Given this list of marker genes NTN1, WDR83 (NCBI Gene Id 84292), DVL2, TGFB1, RORA, MIR2355 (NCBI Gene Id 100423036), TGFB2, NPPB, OVOL2, BMPER, MIR145, NFE2L2, TAL1, NPPC, ITGB1BP1, CEP290, FN1, RBPJ, COL8A2, TMIGD2, NRCAM, PRDM1, ACTG1, COMP, CD40, HMOX1 (heme oxygenase 1), CUL7, C3, TMEM201, HS3ST3A1, KRIT1, ABCC8, TGFA, PPP1R16B, MINAR2, OR10J5, MTHFD1L, STIM1, CDH2, MMP2, CD34, TAFA5, CLEC14A (C-type lectin domain containing 14A), ADGRG6, IL12B, SLC39A12, RLN2 (NCBI Gene Id 6019), OTULIN, MIR1298, ENG, ROCK2, CD47, SEMA5A, MICALL1, CAV1, MIR15A, PTPRJ (protein tyrosine phosphatase receptor type J, NCBI Gene Id 5795), MEIS3, CEMIP2, ST14 (NCBI Gene Id 6768), CSF1, FASLG, SRF, MIR181B1, ARHGAP24, SOX11, TIPARP, EGR3, WNT7B, GATA4, NPNT, RPS7 (ribosomal protein S7), GLMN, ADIPOR2, NCKAP1, CCDC103, WNT6, EHD4, PRKCB, TRIM71, CXCR3, NOTCH3, MTDH, PTGS2, AR, GPX1, TLR3, COL3A1, AMOT, EYA1, MIR483, MIR153-1, RBM15, GDF7, LHX2, ACVRL1, CLDN5, MIR199B, VEZF1, MIR200C, SASH1, CARD10, PRKACB, MAPK7, MYCN, CTSZ, VASH2, ATP5IF1, SEC24B, FGF8, CELA1, SLC12A6, MIR503, PTK2B, GPR4, CSPG4, ZEB1, ECSCR, MCAM, KRAS, ILK, PRKD1 (NCBI Gene Id 5587), CXCL13, TSC1, IRX3, MIR199A1, WNT3A, NR3C1, MIR18A, DNAAF1, PGK1, CCDC39, YJEFN3, AQP1, EDN1, TJP1, ACKR3 (atypical chemokine receptor 3), TSC2, MIR23A, TERT, RDH10, SMAD1, HLA-G, CLIC3, TNFRSF12A, EMC10, RSPO2, IFT57, SARS1, CTSH, WNT11, PIK3C2A (NCBI Gene Id 5286), TBX1, MED1, F3, PDCL3, MIR492, PDCD10, EGFR, CCBE1, NR2E1, ATP2B4, ERBB2, YAP1, KLHL3, STARD13, MIR196A1, FOXC2, EMP2, MIR101-1, FZD3, SMAD3, MTHFR (NCBI Gene Id 4524), NR2F2, CLIC4, MIR495, RSPO3, CHI3L1, MTHFD1, MMRN1, PRKACA, PIK3R6, NOTCH2, MIR99B, GAB1, EGFL8, HESX1, IGFBP7, CXCL17, NKX2-3, COL4A3, TEK, MIRLET7A1, GLI3, IL6, DLL1, HEG1 (NCBI Gene Id 57493), NOX5, BCL2, PDGFA, ANPEP, EPHB3, KDM2B, PF4, SEMA3E, BAK1, LRP2, MAPK14, EFNA1, E2F7, XBP1, MIR146A, CCN2, TBX3, RTN4, MIR31, C1GALT1, DDAH1, PIK3CA (phosphatidylinositol-4,5-bisphosphate 3-kinase catalytic subunit alpha), PRKCA, RELA, HOXA11, CLUAP1, ADAM8, ANGPT2, MIR130A, GPNMB, SPECC1L (sperm antigen with calponin homology and coiled-coil domains 1 like), MIR27A, DLG1, PBX1 (NCBI Gene Id 5087), MIR138-1, MIR185, ANGPTL6, HNF1B, PANK2, CXCL8, TBX5, MIR377, S100A1, PSEN1, JAG1, HAS2, JMJD8, FZD8, MIR16-1, STK3, MIR10A, CCDC40, MIR21, ACVR2B, HSPA12B, SLC31A1, ITGB8, DEAF1, PTCH1, NINJ1, FOXA1, PTPN6 (protein tyrosine phosphatase non-receptor type 6), SEMA4C, CELSR1, SCRIB, BMP4, GTF2I, TNNI3, ITGB3, CASP3, MIA3, RNF207, ANGPTL3, MSX2 (msh homeobox 2), OPTC, MIR92A1, GJC1, LRG1, PROK1, APOB, SYK, SRPX2, MIR137, GLI1, MIR212, APOH, MIR10B, PITX2, ROBO4, RUNX1, NKX2-5, TGFBR1, CASP8, HSPB6, TMEM215, ADTRP (androgen dependent TFPI regulating protein), COL18A1, TNN, CRIPTO, MMP14, KIF20B, CHD7, SOX4, NFIB, CX3CR1, NDNF, MIR206, IL12A, LCN2, PAK1, EFNA3, MIR939, TMEM100, THBS1, MIR143, ACVR1, MIB1, SULF1, ANG, TACSTD2, PLCD3, ADM, B4GALT1, MIR221, AMOTL1, ITGA2B, HS3ST3B1, SP1, EGLN1, PFN1, CTNNB1, MKKS, OSR1, PRL, BMP2, MIR125B1, HMGA2, HRG, DDR1, NCL, NTRK1, PRICKLE1, VEGFA, PHACTR4, ZEB2, ITGAX, FUZ, GREB1L, CCL11, HOXD13, BCAS3, GDNF, SEMA4A, MYDGF, CD93, PKM, ITGA5, ETV5, EPHA4, APLNR, TBX4, VEGFB, GATA2, SPINT2, JMJD6, HYAL1, STIL, EXT1, CDK20, PDCD6, HIPK2, FGF10, HTATIP2, MIR29B1, AGO1, NUP50, SDCCAG8, KLF2, NF1, RGMA, MIR29A, MIR505, MIR205, ADM2, EIF2AK3 (eukaryotic translation initiation factor 2 alpha kinase 3), CCDC134, NPR3, AKT3, S1PR1, GNA13, BAX, GBX2, MIR320A, CD160, NAXE, RYR2, MMRN2, SMAD2, TWIST1, CCN3, DVL1, MIR424, DLL4, TNC, WARS1, AAMP, ECM1, MIR487B, DCN, ITGB1, TSPAN12 (tetraspanin 12), CTHRC1, MYOCD, MIR451A, RALA, RRAS, NGFR, NTRK2, MIR20A, C2CD3, MESP1, VPS4B, ZC3H12A, E2F8, BTRC, ROBO1, IL10, MICAL2, WNT2, NODAL, BBS5, PAX2, SAT1, RARG, WNK1, DAB2IP, CTNNBIP1, MTSS1, FGFR1, PODXL, TSPAN18, KLK3, ESRP2, MET, LIAS, IL18, ABL1, PTK2, VDR, TULP3, MIR106B, EPB41L5, MIR378A, ITGB2, MIR15B, PGF, HIPK1, STK4, BCL2L11, COL8A1, AGO2, MIR375, PDE3B, TGFBR2, OPA1, GPC3, SMOC2, HSPG2, EMX2, FOXD1, EPHB2, S100A7, MIR30E, UBP1, CASR, RIN2, KDM5B, STAB2, ADAM12, CCR2, C3AR1, FOXN4, COL15A1, SHH, SPINK5, FGF2 (NCBI Gene Id 2247), EPN1, MIR30B, ARHGAP22, ADGRB2, CREB3L1, HIF1AN, NRXN3, EGF, GZF1, MIR22, SALL4, PECAM1, SIRT6, SEMA6A, IL1B, MIR34C, FOXF1, STAT3, MINAR1, PAXIP1, TGM2, FYN, TIMELESS, EPHA1 (NCBI Gene Id 2041), RECK, IFT172, NRP1, SOX10, C5AR1, PAX8, HTN1, NIPBL, PAK4, PERCC1 (NCBI Gene Id 105371045), TNMD, PROK2, LOXL2, PPARG, HAND2 (NCBI Gene Id 9464), ALOX5, TRAF6, MED12, CX3CL1, HS6ST1, RAMP1, SPINT1, ADAMTS16, YWHAZ, ADGRB3, CDH13, BMPR1A, PRCP, PKNOX1, GHSR, PLCG1, WASF2, HOXA3, ERAP1, SIX4 (SIX homeobox 4), EPGN (epithelial mitogen), ESR1, MIR29C, TNFAIP2, BRD2, THSD7A, NFATC4, APLN, TFAP2C, STAT1 (NCBI Gene Id 6772), SCG2, ZMIZ1, PIK3R3, MYO18B, SIX1, ESM1, NAA15, SOX8, QKI, SOX18, NRXN1, TYMP, MIR222, MIR1908, LOX, MDK, MIR30C1, TNFAIP3, SPRY2, MECP2, WARS2 (NCBI Gene Id 10352), VAV2, EDNRA, FGFBP1, ZNF304, ANGPTL4, FUT1 (NCBI Gene Id 2523), FLT1, TCF21, SUFU, IHH, HEY2, BCL10, GRHL3, EPHB1, FOXJ2, RNF213, ARID2, BMP5, MIR214, STAB1, LRP1, EDAR, GADD45A, DLG5, AGTR1, LDLR, NOG, HES1, EPN2, FOXP1, FOXO4, CD36, PDPK1, FAP, SPHK1, SMAD4, MEIS1, CYP1B1, BTG1, WNT9B, ADAMTS9, KAT2A, EMILIN2, RAPGEF2, STRA6, IGF1, NRARP, MMP19, NEDD4 (NCBI Gene Id 4734), HAND1, MIR17 (NCBI Gene Id 406952), E2F2, DACT1, ENPEP, ATP5F1B, FOXC1, CIB1, ZNF354C, AHI1, SHB, MIR410, MIR150, SERPINF1, FGF16, MYLK, SOS1, ITGAV, SFRP2, SERPINF2, RET, TMED2, GATA6, HOXB7, TBXA2R, MIR1224, HEY1, MIR132, CDH5, CCN1, FZD4, ROCK1, MIR125A, CSMD1, CCN6, SERPINE1, FZD5, NDP, MIR149, PRKX, IRX2, APOLD1, KIF26B, MAGED1, MIRLET7F1, EDN2, PDGFRA, HES5, CITED1, ASB4, CXCL10, PRKD2, RARA, SOX17, MIRLET7G, MIRLET7B, ADGRA2, SETDB2, SPARC, HOXD11, GPR15, PACSIN2, SOX9, GRHL2, FBLN5, JUN, AIMP1 (aminoacyl tRNA synthetase complex interacting multifunctional protein 1), FOXN1, SHOX2, SPI1, MIR20B, MIR193A, FMNL3, BMPR2, CYBB, CCL2, VASH1, CAV3, LAMA5, ADGRF5, IFT52 (NCBI Gene Id 51098), NUS1, SLC1A1, POFUT1, NR4A3, DAG1, C1orf54, FGFR2, EPHA7, GJA5, FOLR1, NRP2, AGTR2, SRC (NCBI Gene Id 6714), ZFPM2, DSG2, PKD2, DCHS1, APAF1, BCAM, CNMD, GPLD1, KDR, ANXA1 (annexin A1), PTK7 (protein tyrosine kinase 7 (inactive)), ATOH8, BMP7, THBS4, HGS, SHC1, CITED2, ANGPT1, ZFP36L1, HOXA7, GHRL, HOXA1, NPRL3, NAGLU, BBS7, PKD1 (NCBI Gene Id 5310), AGGF1, NDRG4, SKI, MIR19A, STOX1, RASIP1 (NCBI Gene Id 54922), FGF18, WNK4, EDA, MIR329-1, RGCC, EMILIN1, LBX1, CAMP, CECR2, THBS2, ADGRG1, IL17F, TFAP2B, KRT1, FKBP10, NKX3-1, MIR640, RNH1, ATF2, VANGL2, PPP3R1, PTPRB, ADAMTS1, PPP1CA, LMO4, ANGPT4, IL1A, SMO, HHIP, MIR494, EPHB4, WNT2B, SGCD, CMA1, APOD, LAMA1, HIF1A, VEGFD, SALL1, APOE, WT1, PML, JAK1 (Janus kinase 1), APELA, FGF9, ETV2, THY1, TGFBR3, JUP (junction plakoglobin), KLF4 (NCBI Gene Id 9314), CEACAM1, VEGFC, HMGB1, GLUL, JUNB, ALX1, ARHGAP35, CCL24, LZTS2, IRX1, SOSTDC1, PARVA, HOXB3, FOXH1, MEOX2, TGIF1, NKX2-1 (NK2 homeobox 1), ANXA3, MIR342, RHOA (ras homolog family member A), ADAMTS12, MIR26A1, RAMP2, MIR217, RAPGEF3, TCAP, TMEM59L, LRP5, FZD6, EFNB2, GATA3, MIR885, ARL13B, FKBPL, CALCRL, RHOB, CSF1R, MIR497, HPSE, CSNK2B, CCM2 (CCM2 scaffold protein), MEF2C, MIR34A (microRNA 34a), PIK3CB, PIK3CG, TGFBI, COL4A2, GRN, NOS3, MYO1E (NCBI Gene Id 4643), PIK3CD, HOXB13, TCTN1, VSTM4, GDF2, PLXND1, WNT7A, LGR4, TNF, RASA1, EREG, DLC1, ISM1, VASP, WNT5A, PTGIS, PRRX1, AGT (angiotensinogen), NOTCH4, ID1, NOTCH1, TNFSF12, FGF1, SH2D2A, HSPB1, PDGFRB, ANXA2, LGR5, TEAD2, CTNND1, MIR200B, SIX2, GREM1, TBX20, SPRED1, FGF6, MIR361, TP63, PROX1, LEP, MIR34B, SYNJ2BP, JAM3, PXDN (NCBI Gene Id 7837), MYC, NOTO, NFATC3, HS2ST1, MAP2K5, WNT4, COBL, MIR1-1, TIE1, ADAM15, MIR27B, ZIC3, UNC5B, PGR (NCBI Gene Id 5241), CHRNA7 (cholinergic receptor nicotinic alpha 7 subunit), MIR210, LHX1, SIRT1, LEPR, SFRP5, MIR296, CFL1, SPRY1, SP100, SLIT2, AKT1, EPAS1, BSG, EFEMP2, BRCA1, PLK2, HK2, WNT1 (Wnt family member 1), CCR3, SRPK2, HPGD, PLXNB2, ELK3, HHEX, SFRP1, MKS1, ID2, ASB2, HOXA5, KLF5, NPR1, PHB2, SLC12A2 (solute carrier family 12 member 2), HOXA13, MIR19B1, MIR30A (NCBI Gene Id 407029), TP73, AGR2, ETS1, JCAD, SMAD7, PKHD1 (PKHD1 ciliary IPT domain containing fibrocystin/polyductin), SDC4, MFGE8, NPHP3, CC2D2A, RHOJ, GLI2, AMOTL2, MEGF8, RBPMS2, HIF3A, LEF1, EGFL7, PERP, ADGRB1, NOX1, MIR24-1, HLX, HDAC5, MYH9, RAP1A, SGPL1, BBS4, NPR2, PTPRM, TBX2, ISL1, IFT122, PLXDC1, VAV3, COL4A1, HDAC7 (NCBI Gene Id 51564), EPHA2, NR4A1, MEIS3P1, PDGFB, MIR126, LUZP1, FLT4, HDAC9, AREG, here is a description of the gene set: The process in which the anatomical structures of a tube are generated and organized. Epithelial and endothelial tubes transport gases, liquids and cells from one site to another and form the basic structure of many organs and tissues, with tube shape and organization varying from the single-celled excretory organ in Caenorhabditis elegans to the branching trees of the mammalian kidney and insect tracheal system. species: Homo sapiens Human Gene Set: GOBP_TUBE_MORPHOGENESIS